Given this list of marker genes LAMB3, MKKS, ITGA6, ITGB4, PKP1, LAMC2, ZMYM2, LAMA3, TERT, COL7A1, MMP1, CDC45, FLT4, PLEC, POLA1, TINF2, FERMT1, here is a description of the gene set: Human Gene Set: HP_URETHRAL_STRICTURE studied in species Homo sapiens Narrowing of the urethra associated with inflammation or scar tissue. Urethral stricture